Given this list of marker genes Clcf1, Eef2k, Bag1, Twf2, Actr2, Epha4, Mir124a-2, Flrt3, Opa1, Nefl, Plxnb1, Mdk, Tnf, Bmp2, Ascl1, Prpf19, Trpc5, Id4, Ntn1, Pou4f2, Dbnl, Lrrn3, Mfn1 (NCBI Gene Id 69518), Eif2b2, Braf, Dixdc1, Nrdc, Nptn, Robo2, Bhlhb9, Lrrn1, Amigo3, Dscam, Lrrc4b (leucine rich repeat containing 4B), Lrrtm2, Wnt2, Marcks, Serpinf1, Nap1l1, Ache (acetylcholinesterase), Vegfa, Chodl, Cask, Enpp2, Flt1, Fxn, Kdr, Lig4, Ace, Mir219a-2, Tgfb1, Spint1, Sox8, Prl2c2, Slitrk6, Map6, Clcn2, Ephb3, Mag, Plag1 (NCBI Gene Id 56711), Hdac6 (NCBI Gene Id 20374), Ntrk1, Prmt5, Shtn1, Dnm1l, Gfap, Rassf10, Oprm1, Bex1, Myrf, Stk11, Zeb2, Met, Efna5, Gsx2, Cdh4, Wnt3a, Gh, Dcx, Adgrl2, Map1b, Pik3r1, Il1b, Egr2, Macf1, Nkx2-2, Agrn, Nlgn1, Jade2, Gsk3b, Zfp488, Ube2v2, Fn1, Tgm2, Reln, Zfp365, Xlr3b, Nrp1, Ephb1, Mfn2, Flrt2 (NCBI Gene Id 399558), Arhgap32, Itgb1, Caprin2, Myb, Trp73, Ptprd, Mup20, Grid2, Otp, Mir124a-1, Lrp1, Wnt3, Slitrk1, Eif4g2, Lrp2, Wnt7a, Egfr, Bcl11a, Adnp (activity-dependent neuroprotective protein), Ell3, Islr2, Cux2, Lrrc24, Slc30a1, Dag1, Myc, Golga4, Adgrb1, Xrcc2, Stau2, Caprin1, Ctnnb1, Cdon, Rheb, Notch1, Man2a1, Hap1, Ephb2, Ndel1, Adgrl3, Cdkl5, Akap5, Fgf2, Nog, Ntrk2, Rpl4, Grip1, Il34, Tnfrsf12a, Vim, Iqsec1, Robo1, Myo5b, Camk2b, Id2, Ep300, Vegfc, Lrp8, Skil, Hif1a, Trim32, Cyfip1, Plxnc1, Lrrtm1, Nrxn1, Dicer1, Lingo2, Cxcr4, Megf8, Synj1, Nkx6-2 (NK6 homeobox 2), Pparg, Sema4d, Fzd4, Rnf112, Mapk8, Stk25, Nr2e1 (nuclear receptor subfamily 2, group E, member 1), Numbl, Cbln2, Mecp2, Ppp1cc, Adgrb3, Cul7 (NCBI Gene Id 66515), Mtor, Ifng, Baiap2, Ghrl, Khdc3, Dlg5, Thbs2 (NCBI Gene Id 21826), Mir124a-3, Clstn2, Hdac2, Star, Kras, Disc1, Adgrb2, Mir23a, Crabp2, Ankrd27, Actr3, Ptprf, Flrt1, Dct, Sema5a, Zfyve27, Fzd3, Kit, Slitrk2 (NCBI Gene Id 245450), Prkci, Bmpr2, Rgs14, Tiam2, Mir219a-1, Amigo2, Smurf1, St8sia2, Fbxw8, Tspo, Slit2, Tnik, Smarcd3, Picalm, Srrt, Rela, Limk1, Etv5, Il33, Prkch, Ctf2, Grm5, Sh3glb1, Apoe, Numb, Lif, Cxcl12, Fbxo31, Vstm5, Lrtm1, Gdi1 (GDP dissociation inhibitor 1), Slitrk3, Iqsec2, Foxg1, Srpx2, Aspm, Il1rapl1, Adgrl4, Nkx6-1, Tiam1, Ufl1, Faim, Pafah1b1, Trak1 (trafficking protein, kinesin binding 1), Anapc2, Gjc2, Clstn1, Plxnb2, Trf, Cx3cl1 (C-X3-C motif chemokine ligand 1), L1cam, Nlgn3, Serpine2, Smo, Kalrn, Ntf3, Cip2a, Plxnb3, Prkca, Shank3 (NCBI Gene Id 58234), Sox2, Aspa, Oxt, Cdkl3, Asic2, Fxr2, Map2k2, Sema4a, Trpv2, Sema7a, Srf (serum response factor), Ptn, Spen, Nkx2-2os, Snw1, Musk, Tpbg, Syndig1, Lingo4, Zfp335, Hdac1, Snap91, Hes1, Ngf, Gper1, Adgre5, Gli3, Afdn, Il6st, Olig2, Cx3cr1, Il1rap, Pias2, Lta, Tenm4, Ptk2, Tle6, Csf1r, Xrcc6, Qki, Shh, Sox11, Lpar3, Mme, Map2k1, Wnt5a, Ptpra (NCBI Gene Id 19262, protein tyrosine phosphatase receptor type A), Ptprz1, Slitrk5, Lrrtm4, Sgk1, Cbln1, Fxr1, Cux1, Drd2, Bin1, Ss18l1, Sox10, Dbn1, Nin, Neurl1a, Ilk, Rtn4, E2f1, Wdr62, Rab21, Metrn, Pak1, Mapt, Dll3, Tbc1d24, Rnd2, Cysltr1, Dlg4, Dmrta2, Oxtr, Fmr1, Itpka, Map3k13, Ntrk3, Xrcc4, Slc7a5, Arrb2, Plxnd1, Il6, Nlgn2, Nrg1, Xrcc5, Pak3, Amigo1, Tlr2, Lyn, Lrrtm3, Parp6, Adgrl1, Adcy10, Dhx36, Kdm1a (lysine (K)-specific demethylase 1A), Slitrk4, Golga2, Lrtm2, Tnfrsf1b, Wls, Rufy3, Pax6, Shox2, Clstn3, Ist1, Bdnf, Igf1, Atxn1, Obsl1, here is a description of the gene set: Any process that activates, maintains or increases the frequency, rate or extent of nervous system development, the origin and formation of nervous tissue. studied in species Mus musculus Mouse Gene Set: GOBP_POSITIVE_REGULATION_OF_NERVOUS_SYSTEM_DEVELOPMENT